The following is a description of a gene set: Human Gene Set: GSE13485_CTRL_VS_DAY1_YF17D_VACCINE_PBMC_DN studied in species Homo sapiens Genes down-regulated in comparison of unstimulated peripheral blood mononuclear cells (PBMC) versus PBMC 1 day after stimulation with YF17D vaccine. from publication Querec TD, Akondy RS, Lee EK, Cao W, Nakaya HI, Teuwen D, Pirani A, Gernert K, Deng J, Marzolf B, Kennedy K, Wu H, Bennouna S, Oluoch H, Miller J, Vencio RZ, Mulligan M, Aderem A, Ahmed R, Pulendran B (PMID 19029902) The immune responses generated by YF-17D by profiling genes in 25 vaccine recipients were accessed at days 1, 3, 7, and 21 post-vaccination compared to pre-vaccination in PBMCs. The immune responses generated by YF-17D by profiling genes in 25 vaccine recipients were accessed at days 1, 3, 7, and 21 post-vaccination compared to pre-vaccination in PBMCs., and this is the list of marker genes: RBM20, GML, PLAAT2, PRKG2, FAM78B, ADAD1, CHST4 (NCBI Gene Id 10164), THY1, EGFR, RAG2, TEX48, GPR26, ZBTB7C, C11orf16, KRTAP4-12, PCDHGB7, ASB17, LINC00265, SLC34A3, ENSG00000235143, SPART-AS1, VWA3A, LINC02043, PAK4, LMX1A, OR7E104P, TNFSF18, RIPPLY1, GARIN2, CTNND2, SLC5A5, TEX44 (NCBI Gene Id 165100), TMEM132D, TYRP1, CHRM2, DNAAF6, VENTXP1 (VENT homeobox pseudogene 1), RIBC2 (RIB43A domain with coiled-coils 2), SMR3B, PCAT19, SCG2, LINC01366 (NCBI Gene Id 257358), PHOX2B, EFCAB5, CD300LB, VN1R2, SPRR2G, POU2AF3, KRT7, AFAP1L2, HCCAT5, SPAAR, MYH14, GAB4, EPOR, PRDM10-DT, CCL11, SMYD5 (SMYD family member 5), CDSN, MAP6, LINC00421, LINC00520, VAX2 (ventral anterior homeobox 2), SMOC1, WDR72, NKD1, ZNF295-AS1, LINC02800 (long intergenic non-protein coding RNA 2800), C5orf58, CFAP69, CMYA5, CAMK2A, LINC00858, ACKR2, REN, TGIF2LY, OR1C1, TAS2R7 (NCBI Gene Id 50837), WNT2, SLC22A8, SOX13, ITGB6, ZBED3-AS1, RSU1P2, TUBAL3, CNNM2, DYNLT2, PCDHB1, CSH1 (chorionic somatomammotropin hormone 1), PPP1R1B, SPATA24, MMP2, PKD1L2, GRM6, ZNF236 (NCBI Gene Id 7776), RFLNA, MGAT4D, CYP2B6, MMP20, ZNF740, E2F4, FRMPD1, PCLO, FBXL18, CCDC60, TRPC7, MIR3150BHG, HAGLR, FKBP6P2, USH1C, KRT18, HOTTIP, SPRR3, CPN2, GNG4, ARHGEF39, GRIK1-AS1, LGALS14, ARFGEF3, LINC01346, SPHKAP, OMD, N6AMT1, CLDN19, FAM193B, IL17RC, SRRM3, RNASE11-AS1, SPAM1, ANKRD53, MIR205HG, CA14, DCST1, SERPINA6, ADAMTS9-AS2, MKS1, GRPR, LIAT1, LINC00934, INSL4, CSRP3, CERS3, CFAP157, CYP3A7, INTS4P1, PAX9, MEP1B, TIMM23B, KMT2E-AS1, NUDT10, SCUBE2, VSTM2B-DT, ZNF548, PCYT2, ZNF861P, CACNG4, CCHCR1, USP5, LINC01512, IL11, APLNR, OR2A4, PICSAR, SV2C, C2orf81, MAS1, LINC02363, SYPL2, GSX1, EMID1, CFAP74, PODN, MYOZ3, OTUB2, SLCO1A2, GK2, LZTS2, FRMD1, C22orf15, ASB12, WFDC1, MAPK12, SALL3, PLA2G10